Given this list of marker genes SNX16, GCC2, ATG14, PIK3C3 (NCBI Gene Id 5289), AP3B1, NCOA4, GGA3, HGS, GNPTG, SCARB2, HSPA8, VPS53, PIK3R4, CLU, SORL1, M6PR, NDP, AP4M1, VPS4A, NAGPA, ZFYVE16, BECN1, WASH3P, GNPTAB, VPS54, NEDD4, LAPTM5, SORT1, RAB7A, AP3M1, LAMP2, here is a description of the gene set: Human Gene Set: GOBP_PROTEIN_TARGETING_TO_LYSOSOME The process of directing proteins towards the lysosome using signals contained within the protein. studied in species Homo sapiens